The following is a description of a gene set: The chemical reactions and pathways involving the transfer of one-carbon units in various oxidation states. studied in species Mus musculus Mouse Gene Set: GOBP_ONE_CARBON_METABOLIC_PROCESS, and this is the list of marker genes: Mthfd2, Mat1a, Aldh1l1, Mthfr (methylenetetrahydrofolate reductase), Mthfd1l, Mthfd1, Mthfs, Sardh, Mthfd2l, Dmgdh, Gnmt, Ftcd, Shmt1, Mat2b, Sfxn1, Mthfsl, Tyms, Ahcyl1, Aldh1l2, Mat2a, Dhfr, Shmt2, Sfxn3, Fpgs, Ahcyl2, Ahcy